Given this list of marker genes Frmpd4, Vps25, Ndp, Ebag9, Nebl, Uba5, Prpf4 (NCBI Gene Id 70052), Hirip3, Psrc1, Skida1, Zfp507, Dhrs4, Xpo7, Leprot, Slc38a10 (NCBI Gene Id 72055), Map2k4, Vav3, Spag16 (sperm associated antigen 16), Plppr4, Tmprss11e, Mmachc, Ncoa2, Tshr, Gabrr2, Armc10, Ankrd29, Psmb11, Zfp810, Tesk2, Garin5b, Car7, A630023A22Rik, Med7, Pla2r1, Cnot2, Mymx, Arl5a, Hapln1, Phf7, Arhgap12, Ccni, Ttc12, Polr3b, Dis3, Strip2, Nlrc4, Hvcn1, Cert1 (NCBI Gene Id 77681), Slc25a5, Rer1, Ttll1, Ifit2, Bmx, Zfp40, Limch1, Epha4, here is a description of the gene set: Genes predicted to be targets of miRBase v22 microRNA mmu_miR_12204_5p in miRDB v6.0 with MirTarget v4 prediction scores > 80 (high confidence targets). studied in species Mus musculus from publication Chen Y, Wang X (PMID 31504780) Mouse Gene Set: MIR_12204_5P